Given this list of marker genes Cited2, Emp2, Sp3 (trans-acting transcription factor 3), Abcg2, Nodal, Junb, Acsl4, Hsf1, Tle6, Sp1, here is a description of the gene set: Mouse Gene Set: GOBP_EMBRYONIC_PROCESS_INVOLVED_IN_FEMALE_PREGNANCY studied in species Mus musculus A reproductive process occurring in the embryo or fetus that allows the embryo or fetus to develop within the mother.